Given this list of marker genes Prdx2 (peroxiredoxin 2), Ncf1, Lbp, Ins2 (NCBI Gene Id 16334), Grn, Lipa, Ins1, Rps19, Slamf8, S100a9 (S100 calcium binding protein A9 (calgranulin B)), Dusp10, here is a description of the gene set: studied in species Mus musculus A phase of elevated metabolic activity, during which oxygen consumption increases following a stimulus as part of an inflammatory response; this leads to the production, by an NADH dependent system, of hydrogen peroxide (H2O2), superoxide anions and hydroxyl radicals, resulting in an increase in their intracellular or extracellular levels. Mouse Gene Set: GOBP_RESPIRATORY_BURST_INVOLVED_IN_INFLAMMATORY_RESPONSE